The following is a description of a gene set: from publication Cisse B, Caton ML, Lehner M, Maeda T, Scheu S, Locksley R, Holmberg D, Zweier C, den Hollander NS, Kant SG, Holter W, Rauch A, Zhuang Y, Reizis B (PMID 18854153) Human Gene Set: GSE12507_PDC_CELL_LINE_VS_IMMATUE_T_CELL_LINE_DN Genes down-regulated in CAL1 cells (plasmacytoid dendritic cells) versus MOLT4 (immature T cells). Analysis of expression profiles of human pDC cell line (CAL1) compared to an immature T cell line (MOLT4) species: Homo sapiens, and this is the list of marker genes: ACSS3 (acyl-CoA synthetase short chain family member 3), ADAMDEC1, GCK, PDE5A, ANKRD33, EFCAB8, NUP210L, TRIM50, SLC19A2, CABYR, SEZ6L, ELOVL5, SHCBP1, KLHL29, RAB27B, MIR708, HEPACAM2, P2RY4, IGF2BP1, ANK2, KLB, PPL, SHOX2, CCDC112, BTD, CLEC4F, PITPNB, GJB4, MIR137, SNX4, COL16A1, NKPD1, CR2, ACSF3, HEATR3, MIR412, BCAP29, PRLH, HAND2, BTG1, MIR181D, MARCHF1, VWA2, LIPI, KIF15, TTC9, ITGA8, DPPA4, IL7, HSD3B2, ITGA6, LCE3B, CTSLP3, KRTAP10-4, STX12, ABCD4, RIMS3, MACROH2A2, MRPS27, VNN1, NAA11, TRIM29, MRC1, NKX2-1, MIR504, MMP19, KRT13, USP6NL (NCBI Gene Id 9712), ADAMTS14, ERN2, PCDHB13, MED24, SPATA9 (spermatogenesis associated 9), RTKN, CSMD3 (CUB and Sushi multiple domains 3), GIMAP3P, KIF4A, BRIX1, GPR17, LIPH, CGNL1, KCNQ4, TMCC2, GDPD4, RHBDD1, MIR541, PPFIBP2 (PPFIA binding protein 2), TNMD, RGS7, CMA1 (NCBI Gene Id 1215), NBEA, COL1A2, PIGR, C1QL4, LEFTY2, ARL8B, CACNG1, BCO1, SHISAL2A, KCTD6, MT-ND1, ATP2B3, ADCYAP1 (NCBI Gene Id 116), EPS8, TMPRSS13, ROS1, MPP3, MC2R, LTBP3, NCF1, GAP43, ESCO2 (establishment of sister chromatid cohesion N-acetyltransferase 2), HDGFL1, TMEM69, POPDC3, TMX1, TBC1D16, OLIG3, GKN1, TRAPPC3, TOMM34, SULT1D1P, USP43, RNASEH2B, TMEM45B, NCS1, KCNJ11, PEPD, RAMP2, CRLF3, RFPL4A, KCNK2 (NCBI Gene Id 3776), CARMIL3, CH25H, CCNG1, CIT, ACOT6, SUN5, DYNC1LI1, TESMIN, HDAC3, ABRA, TBXT, GOLPH3 (golgi phosphoprotein 3)